Given this list of marker genes GPX3, STOM, SOSTDC1, DPPA3, HABP4, NUP210L, MOSPD3, CLDN6, PMAIP1, SLK, LPAR6, ALDH5A1, ANXA1, TEP1, FAM131A, FRY, KIF26A, RAD54B, EFCAB12, SLAIN2, CCZ1, NR3C1, PLCXD3, CCR6 (C-C motif chemokine receptor 6), TMPRSS13, ANTXR2, ERMP1, TKTL2, PHLDA1, SCLY, HYAL6P, NRP1, ADAM12, RNF125, PLK5, LUC7L2, CTSF, BAIAP3, DNAJC3, SPOCK2, NBAS, XYLT1, ADAM5, MIR103A1, AURKB, NDST1, NSMF, FKBP9, BMAL1, ITGB1, CRTC3, MMP14, PLCD1, CLDN11, LTBP4, PTH1R, FAM170B, TLNRD1, IPMK, GRN, ADORA2A, PRR13, CPNE7, PHLPP2, SSH3, ITGA4, SLC2A13, AXIN2, ALPI (alkaline phosphatase, intestinal), CDKN1A, KNTC1, SEPTIN11, TMEM176A, POLA1, KRTAP8-1, CEP350, NIBAN1, RNF216, RORC, GUCA1A, CADPS, DUSP14, NFATC3, KSR1, IL9R, STX11, PLEKHA5, IRF5 (NCBI Gene Id 84729), RC3H2, B3GNT2, FGR, ARHGAP21, GPR155, PLEKHF2, CNGA2, SYNJ1, IGHG3, NOTCH4, GUCY1A2, FUT8, WWP1, TIAM1, ADCY10, NCOR1, LANCL3, AKR1D1, AGRP, UXS1, XIST, ESYT3, C1QB, MFSD6L, ACSBG1, IQGAP1, CYSLTR1, SUSD4, MYO1C, TDRD9, UPP2, PIK3C2A, ANKIB1, SNTB1, EGR1, NCOA1, TSPOAP1, ANKRD6, APBA1, H2AC6, ABR, NEBL, NYNRIN, ATP2B1, C1QA, TRAF3IP2, BHLHE40, DTNB, NPAS1, IGF1, CEP295NL, DKKL1, WAC, TSPAN2, MMP25, SLC2A8, MFAP3L, RND3, APLP2, ASGR2, DTX4, NCKAP1, CGNL1, PEAR1, CHD7, STARD10, DPY19L3, CNTNAP1, ELF4, GPA33, KCNA3, here is a description of the gene set: Human Gene Set: GSE37605_NOD_VS_C57BL6_IRES_GFP_TREG_UP species: Homo sapiens Genes up-regulated in FoxP3-IRES-GFP: NOD T reg (FOXP3+) versus B6 splenocytes. The aim of this study was to quantify the impact of chimeric Foxp3-GFP protein on the Treg cell transcriptional program. from publication Darce J, Rudra D, Li L, Nishio J, Cipolletta D, Rudensky AY, Mathis D, Benoist C (PMID 22579475)